Given this list of marker genes Gjd2, Panx1, Panx2, here is a description of the gene set: electronically inferred by orthology from the curated human pathway part of: Transmission across Electrical Synapses  This event has been computationally inferred from an event that has been demonstrated in another species.<p>The inference is based on the homology mapping from PANTHER. Briefly, reactions for which all involved PhysicalEntities (in input, output and catalyst) have a mapped orthologue/paralogue (for complexes at least 75% of components must have a mapping) are inferred to the other species. studied in species Mus musculus Reactome Pathway: Electric Transmission Across Gap Junctions